Given this list of marker genes SOX9, EDNRA, EDN1, GSC, WNT8A, SFRP1, here is a description of the gene set: species: Homo sapiens The process in which a cell becomes committed to become a neural crest cell. Human Gene Set: GOBP_NEURAL_CREST_CELL_FATE_COMMITMENT